The following is a description of a gene set: from publication Yevshin I, Sharipov R, Kolmykov S, Kondrakhin Y, Kolpakov F (PMID 30445619) Genes containing one or more binding sites for (HOXB4) in their promoter regions (TSS -1000,+100 bp) as identified by GTRD version 20.06 ChIP-seq harmonization. studied in species Homo sapiens Human Gene Set: HOXB4_TARGET_GENES, and this is the list of marker genes: MIS12, ITGB3BP (integrin subunit beta 3 binding protein), RTEL1, MECOM, SAP18, DLG2, USF1, HACD3, CDK6-AS1, CCSER2, LMLN, RPN1, LSM5, NEMP1, HEXA, CSNK1G3, RNASEH2C, ZWINT, ZNF335, GOLIM4, CLDND1, NOD2, LRRC1, BRCA1, NOL7, IFIH1, SMARCD2, GTF3C4, TTC1, MGAT1, KANK1, ANKHD1-EIF4EBP3, RPS6KL1, TM9SF1, RNA5SP473, LCLAT1, ACYP1, AHI1-DT, TXN, DHTKD1, GLIPR1L2, PARP2, DUT-AS1, ZNF346, CERNA3, EBP, WASHC4, CYP39A1, NFE2L2 (NCBI Gene Id 4780), TEX14, CFAP298, TJP2, CEP70, IMMT, LINC01623, ENSG00000257184, AHI1, ENSG00000254007, PSMD6, ANAPC13, VILL, EWSAT1, CDK19, GET4, MVD, CEMP1, GPNMB, CDPF1, NOXA1, PPP4R1, FAM221A, MZT2A, EFNA4-EFNA3, GLRA1, SAE1, RNF44 (ring finger protein 44), ESR2, MUC1, RHOF, SYBU-AS1, SACM1L, ALDH2, NDUFV1, HES2, MAML1 (mastermind like transcriptional coactivator 1), CIAPIN1, DDIT4, VKORC1, ACTR6, UFSP2, UBE2B, LEMD2, STAG3L5P, ZHX1-C8orf76, CLRN3, DDX41, RAVER1, PSME2P3, GTF2A1, STMN3, FICD, GARS1, ZNF180, RNF14, NAT10, POLG-DT, LARP4, PCYT1A, STPG1, KCNJ5, CDKN1C, ZNF561, LAMTOR5 (late endosomal/lysosomal adaptor, MAPK and MTOR activator 5), ZC2HC1C, HNRNPH1, TNFRSF1A, ILF3, RASSF6, ABLIM2, BMAL1, RTCA, APLF, AHCTF1, GTPBP8, TIMELESS, POLG, PLD1, RPL17-C18orf32, ANKRD54, ARMH4, NAA38, NUP85, AKT1S1, GTF3A, SMG7-AS1, COQ4, KLF7, AVL9, ANKRD19P, TMEM263-DT, PSMA2, DERL2, REL, STARD3, GTF2A1-AS1, RMDN2, PLEKHA6, TRIT1, EIF4A1, MAP7, KAT14 (NCBI Gene Id 96680), USP2, SLC16A10, POP5, MITD1, COMMD8, NUP62 (NCBI Gene Id 51551), MYO15B, NDUFA2, AXDND1, CYB5R4, HERC1, SYBU, MIR7-3HG, ZSCAN26, ZBTB45, ENSG00000265055, PRR4, COX15, CRKL, STAT2, NUDT3, APMAP, LYSMD3, AP1M2, ELOVL5, KCTD14, YARS2, RAD1, STX4, PTPA, RAB40C, PSMA3-AS1, ZNF740, RRP15, PUSL1, B9D1, ZFP90, SGF29, ATF5, PCBP2, SDCBP2, UNC13D, APPBP2-DT, EFL1, RRM2B, LRRFIP2, LINC00265, ZNF398, CIRBP, LINC02453, PDCL3, SH3RF2, SLC52A3, LINC02313, C1GALT1, MEF2D, SECISBP2, TUT1, HYAL3, ENSG00000232732, GTF2B (NCBI Gene Id 2959), COL6A4P1, TICRR (NCBI Gene Id 90381), BCL3, SNORD55, PIAS1, ZNF131, FAM174A-DT, ANXA2R, RRM1, ATP1A3, SEC1P, HDAC4, TBC1D7, FBXL8, SMAD7, URB1-AS1, MIR4665, MRPS27, TRPM7, MYL12B, ELMOD3, CTDSPL2-DT, ZNF641, SKOR1-AS1, XPO1, SOCS2-AS1, PKM, LINC00511, STOML2, CARNMT1, GIRGL (glutamine insufficiency regulator of glutaminase lncRNA), ATN1, PTRH2, CD320, WDR6, NRL, POLR1B, ZNF892, TBC1D22A, CEP57, MARVELD2, PANK3, POLR1A, CDCA8, TMEM80, UQCRQ, MAST4, HMOX2, TTLL1, SRSF11, MTHFD1L, DNAAF4, USP40, RPPH1, LTK, MAPDA, ID1, WDR26, KRR1, MFSD8, SLC2A13, CCL20, ANKS3, WRAP73, TET2, CFAP96, IFT74, TP53BP1, TIMMDC1-DT, MRPL46, AFF4-DT, RAB35, KDM6A, BCL10-AS1, DLGAP1-AS2, GTF2H3, CHMP4C, MLXIP, SF3B6, AREG, LRBA, SNX27, PTMA, OGFRL1, PRPF40B, PSMB1, ERH, ADIPOR2, TAF1B (NCBI Gene Id 9014), ST20-MTHFS, REXO5, ZNF713, H2BC15 (NCBI Gene Id 8341), HECTD4, SNORA13, DUSP28, ASNS, SREBF2, TFCP2, BHLHE40, RNA5SP60 (NCBI Gene Id 100873295), RCHY1, MMACHC, POLA2, LINC02983, GALNT16-AS1, TMEM217, BANP, MIRLET7IHG (MIRLET7I host gene), IL23A, DNAAF4-CCPG1, RNF115, ATP6V1D, MGAT4B, PSD, ASF1B, PIBF1 (progesterone immunomodulatory binding factor 1), ZDHHC12, C19orf47, SYNGAP1, CCDC186, SNAP25-AS1, SH2D3A, SYNRG, MRM1, EPDR1, ARID4A (NCBI Gene Id 5926), ANTXR2, OSBPL10, TRMT13, ANAPC7, PABPN1, PRKACB-DT, LIN7C, RPS20, ZNF584, CCNG1, EXD1, PLEC, GSPT1, MRPL13, CUTA (cutA divalent cation tolerance homolog), FAM151B-DT, RNH1, MCOLN1, EEF1AKMT1, SLC25A40 (NCBI Gene Id 55972), ADGRF4, MATCAP1, FAM220A, EIF5, PTPN13, WAPL, PRH1, MAPK10, FASTK, SEC63, TEDC2-AS1, ZNF629, TRUB2, ATG2A, XAB2, AP3B2, HMGB3P22, FAM156A, HSPA6, RPS15, CSKMT, ATP8B3, PLOD3, PYGO2, DPP9, RFX1, DOCK8-AS2, TCP11L1, EHD4, DDX59, GINS3, SNORA65, ZNF684, EIF3F, TMEM263, HSP90AB1, MIR191, ANK3, SPPL3, NUDT4 (NCBI Gene Id 57236), RNF216, SLC12A9, SPOP, SNX10-AS1, TMEM65, MKRN1, TPM1, SOS1, ERI1, TBC1D17, ACKR2, MRRF, REEP4, LINC00674, METTL4, HSD17B6, MTBP, RPL27, RGS2, KLRG1, UIMC1, CASP8AP2, PLD6, NCOA7, NWD1, TK2, FAM228B, ELF2, STAU1, C1orf52, FBXL12, CELSR3, YAP1, NAA80, RETREG3, NADK, BORCS5, TRMU, RIN1, ZNF184, CTSL, CCDC163, TOB1, APH1A (NCBI Gene Id 82089, aph-1 homolog A, gamma-secretase subunit), ATG3, FAM133B, GOSR1, DMAP1, SLC35A3, CLHC1 (NCBI Gene Id 130162), KDM1A, ENSG00000277020, EMC6, MFAP3, CHID1, LIMCH1, HMBS, SLC35A5, CNOT10 (CCR4-NOT transcription complex subunit 10), NAMPT, SLC9A4, DUT, STK17A, SLC50A1, RBBP9, DPP3, EIF2S1, DFFA, KRT8 (NCBI Gene Id 90177), ULK4, TRIM56, PPP1R14B-AS1, MYL5, IDI1, ATXN2L, ABCC5, ZNF436-AS1, MCAT, TTC22, IQCH, CNPY2, ERCC5, CREBL2, XYLB, BLTP1, MRS2, LINC01424, EZH1, NOL3, OR1F12P (olfactory receptor family 1 subfamily F member 12, pseudogene), POLR3D, PGS1, COPB2-DT, TPRG1-AS1, SVOP, PRORP, ZSWIM9, TSSC4, ZNF777, RBM18, DHCR7-DT, DDX31, ZMAT5, NDUFV1-DT, TMOD3, PNPT1 (polyribonucleotide nucleotidyltransferase 1), COPB2, LINC00667, FIS1, VPS52, M6PR, RC3H2, FAM114A2, IK, CCDC191, PIP4K2B, DNAJB6P3, TPD52L2, SPNS1, KPNB1-DT, ENSG00000282904, ATOSA, TBC1D5, GDAP2, AGPS, APPBP2, CYP4F12, MIR4455, PET100 (NCBI Gene Id 554363), FIP1L1, FAM241B, EIF2B1, TST, AARS2, NOC3L, AJUBA, ENSG00000241525, WDFY3, DPP8, GPATCH11, STXBP3, SMTN, PHF13, H2AC13, CERS5, TTC3, SWSAP1, TBX6, RPS8, H2AC11, ILVBL, HASPIN, ANP32E, PPIL2, SNHG8, RNU2-17P, RAB33B-AS1, QTRT2, SLC35B3, MYL12-AS1, FARSA, STAT1, ZNF598, TNPO2, ATP5IF1, FAM120AOS, ISCU, NAGA, SLC39A6, HOXC-AS2, SDCBP, REL-DT, EBLN3P, SOCS2, FAM76B, HILPDA, AHCYL2, DEAF1 (DEAF1 transcription factor), NR2C1, SLC39A9 (NCBI Gene Id 55334), RBM47, DDI2, CHD1, MRPS11, USP2-AS1, NET1, MRPL49, DPP3-DT, EFNA4, SCAND2P, CS, DPY19L4, TYMS, PLK3, PLS1, PSMC5, TRIP4, ATAD1, ABHD4, FGFR1OP2, SPINT1-AS1, CCDC24, OSBP, CD109, CENPH, BCDIN3D-AS1, USP19, NPY1R, GBA2, PRIM1, RBM7, ARMC8, GOLGA5, REEP5, NPM3, WWOX, FAM168A, DBP, ACAP3, STK25, EPRS1, ZMYND12, LAMTOR5-AS1, LMF1, MRPL36, GARRE1, SMOX, MRPL37, SNRNP40, COA8, SNORA24 (small nucleolar RNA, H/ACA box 24), RNU12, RASGEF1B, TRIP11, PPP4R1-AS1, NMRAL1, MAN1A1, ARMC10, CHORDC1P1, CREB1, RPS27A, SNRPE, SLC39A1, SETD5, CCT2, BARHL1, PRKAG1, AASDH, EEFSEC, HAUS8, ATAD2B, ST20, CRAT, LRRC8D, GPATCH8, TOR1AIP1, ZHX1, SIVA1, KIAA0825, MIRLET7BHG, SARM1, ERMP1, TULP3, COX5A, VMP1, RAD51C, G3BP2, TARS1-DT, SH2B2, OAT, SLTM, MIR320A, NAMPT-AS1, RLIG1, C11orf98, FZD1, LIN9, ATP5ME, NR4A3, MAP2K5, ARHGEF19, LPCAT3, UBR5-DT, WDR37, H2BC11 (H2B clustered histone 11), HNF4A, HK2-DT, PET117, SNORA70, SCAF11, METTL3 (NCBI Gene Id 95719), MSH5-SAPCD1, IP6K2 (NCBI Gene Id 51447), SNORD54, PKP4, RETSAT (retinol saturase), FIGNL1, LRRC49, WAC, HK2 (NCBI Gene Id 3099), PLBD1-AS1, OARD1, LRCH4, MYO9B, ETNK1, FAAP100, AJUBA-DT, GOSR2-DT (GOSR2 divergent transcript), MNX1, CTNS, HNRNPD-DT, DCUN1D3, GTPBP6, RPS18, INTS13, PDXDC1, MTA2, PCLAF, TRIP6, RNPEP, CKLF, NARF-AS2, ETFA, OSER1-DT, CROCCP2, FBXL3, TUBG1, ASPHD1, CTDSPL2, GANC, REV3L, STYX, DVL2, TSEN34, ZNF497, DNAAF8, SLC25A45, LINC02832 (NCBI Gene Id 105373886), ILF3-DT, CMAS, ODAD1, AFF4, CDKL3, NDUFA5, SIL1, C14orf119, SNX33, LINC02168 (NCBI Gene Id 105371252), C7orf50, MYORG, AMN, CCNL1, NUP88, NDUFV3, TRAF3IP2-AS1, NCDN, THUMPD3-AS1, UBE2W, NACA, MRPS34, HILPDA-AS1 (NCBI Gene Id 102724660), TMEM14C, SAXO5, POM121, EFCAB7, PLAA, ECI1, PPP1R37, GOLGA3, DHCR7, DNM1, WEE2-AS1, TARS1, SMARCA2, LARS2, DYNLRB2, ZNHIT1, LYRM1, TSR3, TLL2, PAN2, SLC25A39, NDC80, TMEM62, ELF3-AS1, BTF3-DT, TWNK, CDCA7L, STAP2, TTC31, ACSL1, COX7A2L, PDE4C, TAF6, ANKRD40, PYCR2, DNAJB12 (NCBI Gene Id 54788), HECTD1, EPHX2, LIG1, TNFSF9, CFAP298-TCP10L, ENSG00000213963, POLDIP3 (DNA polymerase delta interacting protein 3), COQ10B, WBP2, KGD4, R3HDM4, TIMMDC1, SNORD58B, MRPS31, TBP, SMPD4BP, ZNF687, SURF1, OSER1, SEC24A, SERTAD3, SNORD95, SAMD4B, ZCCHC17, ACAP2, ERI2 (NCBI Gene Id 730570), SERTAD4-AS1, AMER1, MIR3913-1, CHPT1, STEAP2, NARF, EHD1, CNOT1, TEX264, PPP2R3C, MIR4521, KIAA0319L, IGF2BP3, KAT6B, IVD, FBXO24, CYB5RL (NCBI Gene Id 606495), STEAP2-AS1, LINC02963, SLC35B4, TMEM30A-DT, PANK2, FBXO48, SNRNP70, MALINC1, SNAPC3, GPAT3, ZNF687-AS1, WDR4, ID2-AS1, PPP2R5A, HEATR5B, ZNF696 (NCBI Gene Id 79943), MEMO1, ANKHD1, ST3GAL3, MIR6515, LIAT1, ULK3, CCDC90B-AS1, TESK1, TMEM126B, RPLP1, DIP2B, HTR5A, ZDHHC5, R3HDML-AS1, SQSTM1 (NCBI Gene Id 94002), KRT7, PCCB, ABHD5, CFAP299, KPNB1, SCAI, PLBD1, DHCR24-DT, ZNF473, HOTTIP, CIC, CACNB3 (calcium voltage-gated channel auxiliary subunit beta 3), PTPN23-DT, YIPF3, SMG7, SETDB1, VRK2, YKT6, L3MBTL2, EDC3, GPR6, FBL, GSE1, AGPAT3, GATA6-AS1, RPL17, RBM22, RPAP2, BET1, CLIC1, ZNF561-AS1, MYOSLID-AS1, SLC25A6, SHISA5 (shisa family member 5), HDGF, SURF2, CREB3L4, NUP214, SART1, LOH12CR2, CDC73, TRADD, N6AMT1, PPP1R14B, ETNK1-DT, CD109-AS1, NISCH, PRELID3BP5, UBE2G2, ASAH2B, BAG5, TOB1-AS1, WAC-AS1, PEX14, USP54, MCM10, HDAC4-AS1, MDM1, EMC2, SPATS2, CC2D2B, MARCHF3, MORN2, TRMT12, MICU2, PNKP, ADAT3, MXD3, KALRN, RPS4X, VPS13C-DT, IL4I1, MST1P2, OAZ2, UAP1-DT, E4F1, WDPCP, NCKAP5L, PYGO2-AS1, FBXO22, ZNF608, RBM33 (NCBI Gene Id 92454), COPG1, AATF, CACYBP (calcyclin binding protein), PPM1D, RAB27B, GCC1, TATDN3, BRSK2, PCNT, PLD3 (NCBI Gene Id 23646), MSH5, SCARB1, PDE8A, HSP90AA1, TMEM223, RNF19A, SPAG7, FTSJ3 (FtsJ RNA 2'-O-methyltransferase 3), MAPK8IP3, CHCHD2, NSL1, IARS1, PLA2G4E-AS1, SURF6, SCAMP4, DCP1B, HACE1, NXF1, STK40, DIS3, ELP2, MIR3178, HOXA13, ALDH1A3-AS1, MAPK8IP2, TIMM44, DCTN2, MRPS31P4, PHF3, CNPY2-AS1, ALKBH2, ADI1, NSD1, IQCG, CRNKL1, B3GALNT2 (beta-1,3-N-acetylgalactosaminyltransferase 2), PDCD10, TMEM266, ZNF860 (NCBI Gene Id 731296), POLR1C, NLE1, MCUB (mitochondrial calcium uniporter dominant negative subunit beta), POLR2H (RNA polymerase II, I and III subunit H), SNORD16, LIMD1-AS1, RACK1 (NCBI Gene Id 90938), CALR, ZMYM6, CDK6, PGAM5, PDK1, DALRD3, SNORA57, FDPS, SP2, RNU6-8, MACC1, B4GALT2, PPCS, PFKFB4, C2CD2L, CFAP61, EHMT1, CUTC (cutC copper transporter), POLH, HNRNPD, TUBGCP6, CHP1, CSAD, ATP2B1, FAU, TTBK2, SCP2, H2AC15, HMGCR, MDH1 (malate dehydrogenase 1), EME2, PPP2R5C, SART3, POMT2, CNTRL, MTMR9, BCL10, MTMR11, RCN1, KDM3A, MRPL30, RBM4, TMEM30A, NEK9, KPNA4, PPM1F, UACA, C10orf143, ENTPD1-AS1, SAXO2, HNRNPK, CLTB, ABCF1, PTPN4, SAYSD1, HTATSF1P2, SHROOM1, C3orf52, CDKN1B, EIF4G1, NDUFAF3, HGH1, RBM33-DT, PLEKHO2, KIF26A, SPAST (NCBI Gene Id 6683), NASP, SNAI3-AS1, SLC27A3, TMEM52, GSTZ1, TRIM52, PIGP, CFL1P1, CCDC148, EPHB6, PPP2R5B, EPHB3, WDFY3-AS2, EXD2, H2AX, MIR7-3, FBXL13, OGDHL, PURA, GATAD2A, FBXW11, ZBTB11, HEXA-AS1, NBR1, SEH1L, CZIB, JAK2, ELOVL1, SMPDL3A, TMEM39B, YTHDC1, UNKL, KLC4, ATP8B1 (ATPase phospholipid transporting 8B1), ZNF213-AS1, CEP63, MPND, IFT56, SIN3A (NCBI Gene Id 25942), DGAT1, ACTR5, TAS2R14, CENPJ, C12orf76, DRAM1, ARB2A, GTPBP3 (GTP binding protein 3, mitochondrial), TAX1BP3, ERLIN2, MPV17L2, DDX27, GOSR2, ZNF497-AS1, NOD1, RPL9, CCDC134, GATA6, SYNJ1, GOLPH3, SPATA7, RPL7L1, VRK3, PTPN12, FNDC3A, RTCA-AS1, KIF26A-DT, TMEM131, NME9, NFAT5, LRIG2, SNX13 (NCBI Gene Id 23161), LRRC8D-DT, RTN4, RMI1, DYNLRB2-AS1 (DYNLRB2 antisense RNA 1), SPAG9, SEZ6L2, HDHD2, CCDC107, NUDC, MBOAT7, LRRC40, CCDC90B, RARRES1, CCDC142, ZNF410, ACTR3C, SLC12A9-AS1, THAP2, STAG3L5P-PVRIG2P-PILRB, ID3, RTEL1-TNFRSF6B, MRPL43, XPO5, SCAMP5, SAMTOR, C21orf58, EIF2AK4, PPA1, DYNC2I2, CENPQ, MAP7-AS1 (MAP7 antisense RNA 1), PHF19, LINC01852, CYB5D1, IGSF9, WDR27, NDFIP1 (Nedd4 family interacting protein 1), SMIM27, RHEB, CCNDBP1, COQ9, TRPC4AP, XPO7, RPAIN, MATR3, KANSL2, MIR7845, FOXP2, RNU11, SNORD18A, GDF9